The following is a description of a gene set: Human Gene Set: HP_DECREASED_MEAN_CORPUSCULAR_HEMOGLOBIN_CONCENTRATION studied in species Homo sapiens A reduction from the normal range of the average amount of hemoglobin per red blood cell (27 to 31 picograms/cell). A reduced mean corpuscular hemoglobin (MCH) may indicate a hypochromic anemia, but the MCH may be normal if both the total hemoglobin and the red blood cell count are reduced. Decreased mean corpuscular hemoglobin concentration, and this is the list of marker genes: HELLPAR, CD46, CFI, HBB, CFH, RHAG